The following is a description of a gene set: Any process that modulates the frequency, rate or extent of the directed movement of the monoamine neurotransmitter serotonin into a cell. species: Mus musculus Mouse Gene Set: GOBP_REGULATION_OF_SEROTONIN_UPTAKE, and this is the list of marker genes: Gpm6b, Fev, Nos1, Slc18a1, Snca, Itgb3